The following is a description of a gene set: Reactome Pathway: TNFR1-induced NF-kappa-B signaling pathway This event has been computationally inferred from an event that has been demonstrated in another species.<p>The inference is based on the homology mapping from PANTHER. Briefly, reactions for which all involved PhysicalEntities (in input, output and catalyst) have a mapped orthologue/paralogue (for complexes at least 75% of components must have a mapping) are inferred to the other species. part of: TNF signaling electronically inferred by orthology from the curated human pathway species: Mus musculus, and this is the list of marker genes: Usp21 (NCBI Gene Id 30941), Tnfaip3, Cyld, Tab2, Usp4, Otud1, Tnfrsf1a, Ikbkb, Optn, Rack1, Tradd, Tab3, Tnf, Spata2, Ubb, Birc3, Tab1, Traf1, Rps27a